Given this list of marker genes CD48, CPA3, CST7, ATF7IP, SELENOS, MYL1, here is a description of the gene set: Genes up-regulated in DO11.10 cells (hybridoma) by expression of transciptionally activating and by transcriptionally repressive forms of HDAC7. Histone deacetylase 7 (HDAC7) is highly expressed in CD4(+)/CD8(+) thymocytes and functions as a signal-dependent repressor of gene transcription during T-cell development. In this study, we expressed HDAC7 mutant proteins in a T-cell line and use DNA microarrays to identify transcriptional targets of HDAC7 in T cells. The changes in gene expression levels were compared to differential gene expression profiles associated with positive and negative thymic selection. This analysis reveals that HDAC7 regulates an extensive set of genes that are differentially expressed during both positive and negative thymic selection. Many of these genes play important functional roles in thymic selection, primarily via modulating the coupling between antigen receptor engagement and downstream signaling events. Consistent with the model that HDAC7 may play an important role in both positive and negative thymic selection, the expression of distinct HDAC7 mutants or the abrogation of HDAC7 expression can either enhance or inhibit the signal-dependent differentiation of a CD4(+)/CD8(+) cell line. species: Mus musculus from publication Kasler HG, Verdin E (PMID 17470548) Human Gene Set: KASLER_HDAC7_TARGETS_2_UP